The following is a description of a gene set: GPCR-PI3K signaling pathway. Pathway ID: N01657. Pathway type: Reference. Pathway class: nt06530 PI3K signaling. Pathway Definition from KEGG: (GPCR+GNB+GNG) -> PI3Kgamma -> PIP3 -> AKT studied in species Homo sapiens Human Gene Set: KEGG_MEDICUS_REFERENCE_GPCR_PI3K_SIGNALING_PATHWAY, and this is the list of marker genes: LPAR4, GNB5, GNG7, GNG3, GNG12, GNG2, LPAR5, AKT1, GNB2, GNG13, CHRM1, F2R, GNGT1, GNG8, CHRM2, LPAR6, GNB3, AKT2, GNG5, LPAR3, GNB4, GNG4, GNG10, GNGT2, PIK3R5, PIK3CG, LPAR2, PIK3R6, AKT3, LPAR1, GNG11, GNB1 (G protein subunit beta 1)